Given this list of marker genes Mctp1, Alox5ap, Hltf, Upf3b, Tm6sf1, Mapk14, Klf4, Ogt, Gpr65, Gm2a, Ramp1, Cyb5a, St3gal5, Tyrobp, Niban1, Man2b1, Gpx1, Creg1, Ivns1abp, Pid1, Arrb1, Hexa, Mxd4, Septin6, Lmo4, Ccr9, Npm1, Gdi2, Naca, Cd44, Commd8, Unc93b1, Git2, Fos (NCBI Gene Id 14281), Irag2, Jun, Rnase6, Iqgap2, Lyz2, Ttc39a, Nr4a1, Coro1a, Tnrc6b, H2-DMa, Ctdp1, Cox7a2l, Inpp5d, Tlr12, Shtn1, Lipa, Ighm (NCBI Gene Id 432703), Arhgap17, Rab32, Cat, Fxyd5, Parp8, Proser2, Rtl8a, Eef1b2, Klhl24, Camk1d, Cd180, Clec12a, Arhgdib, Itgb7, Pold4, Ptpn18, Mpeg1, Bmyc, Tsc22d3, Cd48, Klf2, Eef2, Pianp, Fau, Otulinl, Trf, Ccdc88a, Celf2, Cxcr3, Sat1, Ccdc12, Pak1, Srsf11, Hepacam2, Rgs10, Ifngr1, Klhl6, Ucp2, Pmaip1, Pld4, Arhgap18, Zfp36l1, Erp29 (endoplasmic reticulum protein 29), Anxa1, Kctd12, Unc119, Evl (NCBI Gene Id 14026), Il16, Cd300c2, Treml4, Zfp36l2, Rgs2, Foxp1, Fosb, Myo1f, Acss1, Eif3e, Rnd3, Arsb, Btg2, Lpar6 (lysophosphatidic acid receptor 6), Cnih4, Rab7b, Ccr2, here is a description of the gene set: Genes negatively differentially expressed in cell type: cDC1 (conventional dendritic cell type 1) upon treatment with cytokine: IL-36α in mouse lymph nodes in vivo. from publication Cui A, Huang T, Li S, Ma A, Pérez JL, Sander C, Keskin DB, Wu CJ, Fraenkel E, Hacohen N (PMID 38057668) Mouse Gene Set: CUI_CDC1_IL36A_RESPONSE_DN studied in species Mus musculus Cytokines mediate cell-cell communication in the immune system and represent important therapeutic targets. A myriad of studies have highlighted their central role in immune function, yet we lack a global view of the cellular responses of each immune cell type to each cytokine. To address this gap, the authors created the Immune Dictionary, a compendium of single-cell transcriptomic profiles of more than 17 immune cell types in response to each of 86 cytokines (>1,400 cytokine-cell type combinations) in mouse lymph nodes in vivo. A cytokine-centric view of the dictionary revealed that most cytokines induce highly cell-type-specific responses. For example, the inflammatory cytokine interleukin-1β induces distinct gene programmes in almost every cell type. A cell-type-centric view of the dictionary identified more than 66 cytokine-driven cellular polarization states across immune cell types, including previously uncharacterized states such as an interleukin-18-induced polyfunctional natural killer cell state.